Given this list of marker genes CRK, NRG2, ERBB4, EGFR, DOK1, RPS27A, NRG3 (NCBI Gene Id 219505), UBC, BCAR1, KHDRBS3, EPAS1, RHOA, LRRK2, KHDRBS1, SOCS3, SRMS, UBA52, RAC1, ELMO2 (NCBI Gene Id 63916), SFPQ, DOCK1, CDKN1B, GPNMB, CCNE1, UBB, EREG, BTC, CDK2 (cyclin dependent kinase 2), HBEGF, EGF, PELP1, CBL, CDK4, PTK6, NRAS, HIF1A, ELMO1, CCND1, STAT3, LINC01139, KRAS, KHDRBS2, AKT1, NRG4, RASA1, NR3C1, PTPN1 (NCBI Gene Id 5770), ARHGAP35, ARAP1, NRG1, ERBB3, PXN, HRAS, ERBB2, STAP2, here is a description of the gene set: species: Homo sapiens Reactome Pathway: Signaling by PTK6 part of: Signaling by Non-Receptor Tyrosine Kinases PTK6 (BRK) is an oncogenic non-receptor tyrosine kinase that functions downstream of ERBB2 (HER2) and other receptor tyrosine kinases, such as EGFR and MET. Since ERBB2 forms heterodimers with EGFR and since MET can heterodimerize with both ERBB2 and EGFR, it is not clear if MET and EGFR activate PTK6 directly or act through ERBB2. Levels of PTK6 increase under hypoxic conditions (Regan Anderson et al. 2013, Pires et al. 2014). The kinase activity of PTK6 is negatively regulated by PTPN1 phosphatase and SRMS kinase, as well as the STAT3 target SOCS3.<p>PTK6 activates STAT3-mediated transcription and may also activate STAT5-mediated transcription. PTK6 promotes cell motility and migration by regulating the activity of RHO GTPases RAC1 and RHOA, and possibly by affecting motility-related kinesins. PTK6 crosstalks with AKT1 and RAS signaling cascades and may be involved in MAPK7 (ERK5) activation. PTK6 enhances EGFR signaling by inhibiting EGFR down-regulation. PTK6 may also enhance signaling by IGF1R and ERBB3.<p>PTK6 promotes cell cycle progression by phosphorylating and inactivating CDK inhibitor CDKN1B (p27).<p>PTK6 activity is upregulated in osteopontin (OPN or SPP1)-mediated signaling, leading to increased VEGF expression via PTK6/NF-kappaB/ATF4 signaling path. PTK6 may therefore play a role in VEGF-dependent tumor angiogenesis.<p>PTK6 binds and phosphorylates several nuclear RNA-binding proteins, including SAM68 family members (KHDRSB1, KHDRSB2 and KHDRSB3) and SFPQ (PSF). The biological role of PTK6 in RNA processing is not known.<p>For a review of PTK6 function, please refer to Goel and Lukong 2015.